Given this list of marker genes NRP2, NRP1, LAMA5, SHH (sonic hedgehog signaling molecule), SEMA3F, here is a description of the gene set: Partitioning of the blastoderm embryo into trunk segmental units. In Drosophila, the trunk segments include thoracic segments and abdominal segments A1 to A8. studied in species Homo sapiens Human Gene Set: GOBP_TRUNK_SEGMENTATION